The following is a description of a gene set: Human Gene Set: GSE17974_0H_VS_2H_IN_VITRO_ACT_CD4_TCELL_UP from publication Elo LL, Järvenpää H, Tuomela S, Raghav S, Ahlfors H, Laurila K, Gupta B, Lund RJ, Tahvanainen J, Hawkins RD, Oresic M, Lähdesmäki H, Rasool O, Rao KV, Aittokallio T, Lahesmaa R (PMID 20620947) Genes up-regulated in comparison of untreated CD4 T cells at 0 h versus the untreated cells at 2 h. The aim of this dataset was to study in detail the transcription kinetics initiated by cytokine IL-4 in early differentiation of Th2 cells. species: Homo sapiens, and this is the list of marker genes: SOCS1, BRD7P3, ADPRM, VPS26B, ZBED10P, BIN2, RAP1GAP2, ALKBH7, SLC2A3, TBC1D22A, EIF2D, ABCA2, R3HDM2, MRPL1, ETHE1, CFL2, PGAP3, ARIH2OS, PTP4A1, HAR1A, KCTD3, NSMCE3, UBASH3B, TYSND1, EIF4E3, CLIP2, GADD45A, ITGA6, ZNF844, ILF3-DT, VIPR1, SLC16A5, TMIGD2, FLOT2, TXK, G0S2, RFXANK, ZBTB10, TPRN, LINC00955, TRIB2, SIAE, CASP1, ERP27, GPR160 (NCBI Gene Id 26996), GALC (galactosylceramidase), MICA, SUCLG2, KLF4, SC5D, PHKB, DHRS7, PNKP, RGS1, ANAPC15, JUNB, CTSH, PTGR3, FYB1, ARHGAP32, FHIT, SIK1, LMF2, GPRASP2, KLHL15 (NCBI Gene Id 80311), SNN, TAFAZZIN, MORC2-AS1, ZMIZ1, XPNPEP3, JUN, MDS2, PET117, GALNT12, KIFC2, WDR13, ARHGEF11, S100A6, FAM13A, UBALD2, TARBP1, MMAB, NTAQ1, VAMP5, LYRM9, SOCS3, EPHX2 (NCBI Gene Id 2053), GMDS, PPP3CC, ENSG00000280119, VNN2, POLR3GL, C16orf74, DUSP1, MMD, FKBP14, BHLHE23, PTPN13, RCSD1, PRKCZ, SCAI, CNBD2, U2AF1L4, ZDHHC14, PTPMT1, TARS2, ZC3HAV1, PDE4B, GABBR1 (NCBI Gene Id 2550), FOS, LINC00173, AJAP1, ASAH1, RNPEP (arginyl aminopeptidase), MCOLN1, FBXO33, ALDH8A1, CD70, ZFAND3, STK16, OXNAD1, PARP3, SAMHD1, TOB1, ITGA4, BMP1, GSAP, ATP6V0E2, FRG1JP, ASPH, C9orf72, CAMK2D, ITGB7, TPD52, EVL, FAM78A, NMRK1, EFHC2, SRD5A1, PCIF1, FAM168A, CD4, ANKRD39, CLDN19, FRAT1, TRABD2A, HEMK1, RNF125, RIPOR2, GSTK1, PCNX2, SLC66A3, ZNF101, DNASE1L1, ACAP1, DTD1, UCP2, CITED2, WAS, UNC119B, ARRDC3, EXD3 (NCBI Gene Id 54932), TMEM141, ST3GAL5 (ST3 beta-galactoside alpha-2,3-sialyltransferase 5), CARINH, RPS6KC1, GSDMB, MELTF-AS1 (MELTF antisense RNA 1), TPM2, HAUS3, EPS8L2, NME4, MAN2B2, DYNLRB1, ALS2CL, FAM200B, NEU4 (NCBI Gene Id 129807), ZNF337, TSC22D1, CDC14A, ANKRD36C, NFKBIZ, RGS2, TBC1D29P, ZBTB20, EIF4G3, ABCC10, CDCA7, PSTK, LDB2, NFIL3, PHF21A, DLG3, POLI, RBM33, ZDHHC11, SLC10A7, PNMA2, PIGA